The following is a description of a gene set: Human Gene Set: MYLLYKANGAS_AMPLIFICATION_HOT_SPOT_7 DNA copy number amplifications activate oncogenes and are hallmarks of nearly all advanced tumors. Amplified genes represent attractive targets for therapy, diagnostics and prognostics. To investigate DNA amplifications in different neoplasms, we performed a bibliomics survey using 838 published chromosomal comparative genomic hybridization studies and collected amplification data at chromosome band resolution from more than 4500 cases. Amplification profiles were determined for 73 distinct neoplasms. Neoplasms were clustered according to the amplification profiles, and frequently amplified chromosomal loci (amplification hot spots) were identified using computational modeling. To investigate the site specificity and mechanisms of gene amplifications, colocalization of amplification hot spots, cancer genes, fragile sites, virus integration sites and gene size cohorts were tested in a statistical framework. Amplification-based clustering demonstrated that cancers with similar etiology, cell-of-origin or topographical location have a tendency to obtain convergent amplification profiles. The identified amplification hot spots were colocalized with the known fragile sites, cancer genes and virus integration sites, but global statistical significance could not be ascertained. Large genes were significantly overrepresented on the fragile sites and the reported amplification hot spots. These findings indicate that amplifications are selected in the cancer tissue environment according to the qualitative traits and localization of cancer genes. studied in species Homo sapiens Amplification hot spot 7: colocalized fragile sites and cancer genes in the 3q26.3-q29 region. from publication Myllykangas S, Himberg J, Böhling T, Nagy B, Hollmén J, Knuutila S (PMID 16751803), and this is the list of marker genes: PIK3CA, RPL22, EIF4A2, MECOM, BCL6, TFRC, LPP